The following is a description of a gene set: studied in species Homo sapiens from publication Pramoonjago P, Baras AS, Moskaluk CA (PMID 16636670) Microarray RNA gene expression profiling analysis has shown that Sox4 (Sry-related high mobility group (HMG) box 4) is one of the most upregulated genes in adenoid cystic carcinoma (ACC), relative to non-neoplastic tissue of origin. Here, we show that Sox4 protein is similarly upregulated in ACC by immunohistochemistry of 28 primary cancers and 20 normal tissues. To elucidate the functional significance of these findings, RNA interference (RNAi)-mediated RNA silencing was used to downregulate Sox4 expression in the ACC-derived cell line, ACC3. With confirmed knockdown of Sox4 protein, cell viability was reduced by 51%, with a corresponding increase of apoptosis to 85% as compared to 12% in controls. Apoptosis was confirmed by cell morphology, DNA fragmentation and flow cytometry. Cells could be rescued from the proapoptotic effects of Sox4 RNAi by co-transfection with a construct expressing functional Sox4. Microarray gene expression profiling of RNAi knockdown experiments shows that downregulation of Sox4-modulated expression of critical genes involved in apoptosis and cell cycle control. Overall, our findings suggest that Sox4 contributes to the malignant phenotype of ACC cells by promoting cell survival. Genes up-regulated in ACC3 cells (adenoid cystic carcinoma) after knockdown of SOX4 by RNAi. Human Gene Set: PRAMOONJAGO_SOX4_TARGETS_UP, and this is the list of marker genes: MXI1, MAFF, BNIP3 (BCL2 interacting protein 3), MYD88, ELF4, STC2, GDF15, CCNL1, TPBG, AK4, AMPD3, NAP1L1, PHF1, TRIM8, CCNG2, RIT1, TNFAIP3, BTN2A1, BTG1, GRB10, SOD2, NDRG1, SERPINE1, PLIN2, KDM3A, RIOK3, CXCR4, ZFP36L1, CAPRIN2, INSIG2, STC1, IER3 (immediate early response 3), NFIL3 (NCBI Gene Id 4783), SMNDC1, CLK1, JUND, BHLHE40, FGD6, RND3, GPRC5A, TIPARP, ARHGAP45, DUSP4, RBCK1, VEGFA, TNIP2, JUN, IL1B, TRIB3, SLC2A3, NAB2, ADM